The following is a description of a gene set: from publication Chen Y, Wang X (PMID 31504780) studied in species Homo sapiens Human Gene Set: MIR330_5P Genes predicted to be targets of miRBase v22 microRNA hsa-miR-330-5p in miRDB v6.0 with MirTarget v4 prediction scores > 80 (high confidence targets)., and this is the list of marker genes: PIP5K1C, DNM1L, HDHD2, ZNF197, VLDLR, ZNF544, ARC, RALGAPA1, RTL8B, MRAS, KCNIP2, AMOTL1, MTCL2 (microtubule crosslinking factor 2), TBC1D16, VDR, ZNF577, SSBP4, WNT7B, MEGF6, WDR91, GDAP2 (ganglioside induced differentiation associated protein 2), FBXO21, PRX (periaxin), KCNH1, TMEM178B, INO80D, OTP, LRRTM1, CD6, ADAM29, ETS1, ABCC1, PIP4K2C, ODR4, ELK4, DYRK3, KLF14, SLC5A3, SKP2, LDOC1, IGF2BP1, PPP4R1, ZZEF1, ANKFY1, ARPP21, IQSEC3 (NCBI Gene Id 440073), GNAO1, PLEC, FNDC3A, SAMD4B, SRGAP3, TNR, CHCHD3, OXSR1, CERS6, SSTR3, MIEF1, ABTB3, CMTM8, VPS39, TOMM40L, XIRP1, BRPF3 (NCBI Gene Id 27154), CMKLR1, MAPK1, CYP8B1, CEP85, GPD2, ATXN1, TIRAP, B4GALT1, PPP1R3F, CFAP70, RUNDC3B, SLC38A2, ALAD, NFATC2, NHS, VCF2, UBXN10, EPHB3, ZNF423, ELK1, LARP1, IQCD, ITGA5, WDFY1, TMTC2, SAMD12, MAGI3, RIMS4, EPHX2, TSPAN14, TSPAN18, SDK2 (NCBI Gene Id 54549), ZNF609, PLEKHM3, MDM1, CD47, BAHD1, SYS1, CDK15, KLK5, PNISR, NGFR (nerve growth factor receptor), CBFA2T3, TOMM34, ZNF322, PTBP1, CNKSR3, NLK, PIK3CG, LETM2, PRKCB, SLC23A2, HAVCR2, CACNA1E, FGF11, PML, GAB1, TANGO6, RAB3IP, TLN1, PARVA, PCNX1, CHRM1, FAM168A, CABLES2, SOBP, EMC8, PPP1R14C, CCDC149, CDH22, PALM, MOB3C, RNASE13, CTXN2, KLHL14, ANKRD6, MAPK4, MTMR8, GLOD5, PAX5, TK2, SLC19A2, EFNA3, NPAS3, GPI, SPRYD3, RALGPS2, TOM1L2, FSHR, TRABD2B, ATP6V1G2, BTNL8, NINJ1, H6PD, METAP1, FRAT2 (NCBI Gene Id 93368), TPBGL, KLF3, SHISA7, EGFLAM, CHL1, UBE2W, NDUFAF4, RIT1, PLEKHG3, KCNQ4, MMP24, RFT1, EPB41L1, GRIPAP1, STK35, SLC27A4, PPIL1, GRM1, CTNS, YBEY, POLR2J3, MGA, SLC24A3, GGT7, MTR